The following is a description of a gene set: Human Gene Set: WORSCHECH_TUMOR_EVASION_AND_TOLEROGENICITY_DN Selected genes with immunologic function which were reciprocally changed in evasion and tolerogenic tumor models. from publication Worschech A, Kmieciak M, Knutson KL, Bear HD, Szalay AA, Wang E, Marincola FM, Manjili MH (PMID 18381452) We have previously shown T-cell-mediated rejection of the neu-overexpressing mammary carcinoma cells (MMC) in wild-type FVB mice. However, following rejection of primary tumors, a fraction of animals experienced a recurrence of a neu antigen-negative variant (ANV) of MMC (tumor evasion model) after a long latency period. In the present study, we determined that T cells derived from wild-type FVB mice can specifically recognize MMC by secreting IFN-gamma and can induce apoptosis of MMC in vitro. Neu transgenic (FVBN202) mice develop spontaneous tumors and cannot reject it (tumor tolerance model). To dissect the mechanisms associated with rejection or tolerance of MMC tumors, we compared transcriptional patterns within the tumor microenvironment of MMC undergoing rejection with those that resisted it either because of tumor evasion/antigen loss recurrence (ANV tumors) or because of intrinsic tolerance mechanisms displayed by the transgenic mice. Gene profiling confirmed that immune rejection is primarily mediated through activation of IFN-stimulated genes and T-cell effector mechanisms. The tumor evasion model showed combined activation of Th1 and Th2 with a deviation toward Th2 and humoral immune responses that failed to achieve rejection likely because of lack of target antigen. Interestingly, the tumor tolerance model instead displayed immune suppression pathways through activation of regulatory mechanisms that included in particular the overexpression of interleukin-10 (IL-10), IL-10 receptor, and suppressor of cytokine signaling (SOCS)-1 and SOCS-3. These data provide a road map for the identification of novel biomarkers of immune responsiveness in clinical trials. species: Mus musculus, and this is the list of marker genes: IRF3, SOCS3, BAK1, LSP1, TOR1AIP2, IL1R2, IL10RB, IL10, TANK, SOCS1, IRF1, IRF6, IFNGR1, TLR6